The following is a description of a gene set: from publication Liberzon A, Birger C, Thorvaldsdóttir H, Ghandi M, Mesirov JP, Tamayo P (PMID 26771021) Genes down-regulated in response to ultraviolet (UV) radiation. species: Homo sapiens Human Gene Set: HALLMARK_UV_RESPONSE_DN, and this is the list of marker genes: DUSP1 (dual specificity phosphatase 1), CDC42BPA, MGLL, SRI, INPP4B, PIK3R3, DBP, ATRN, CCN1, AGGF1, FBLN5, SCAF8, NR3C1, CACNA1A, PRKCA, CDKN1B, ERBB2 (erb-b2 receptor tyrosine kinase 2), RND3, TJP1, MTA1, DDAH1, ATP2C1, PTPRM, FZD2, SPOP, RGS4, ATP2B4, PIK3CD, WDR37, ADGRL2, NIPBL, SCHIP1, PTPN21, LDLR, PIAS3, MIOS, INSIG1, ANXA4, RUNX1, SNAI2, DAB2 (DAB adaptor protein 2, NCBI Gene Id 1601), SYNJ2, SMAD7, SYNE1, PRKAR2B, RXRA, ATP2B1, COL11A1, DLG1, MAGI2, CDON, SIPA1L1, ABCC1, COL1A2 (NCBI Gene Id 1278), KALRN, SCN8A, COL3A1, PLPP3, KCNMA1, GJA1, RBPMS, DLC1, PRDM2, IGFBP5, TOGARAM1, TENT4A, GCNT1, SERPINE1, MAP2K5, NOTCH2, BCKDHB, PDGFRB, PHF3 (PHD finger protein 3), FYN, TGFBR3, VLDLR, F3, PEX14, CELF2, NEK7, MRPS31, BDNF, IGF1R, ADD3, CAP2, NR1D2, TGFBR2, MT1E, SMAD3, NRP1, ITGB3, ADORA2B, HAS2, EFEMP1, CAV1, PPARG, MGMT, VAV2, CDK13, PDLIM5, BMPR1A, AKT3, MET, BHLHE40, APBB2, GRK5, LPAR1, MAP1B, COL5A2, FHL2, ATXN1, ZMIZ1, ICA1, ARHGEF9, TFPI, PTGFR, DYRK1A (dual specificity tyrosine phosphorylation regulated kinase 1A), AMPH, LTBP1, MMP16, LAMC1, DMAC2L, MYC, PRKCE, RASA2, SLC22A18, ID1, CITED2 (Cbp/p300 interacting transactivator with Glu/Asp rich carboxy-terminal domain 2), YTHDC1, PMP22, NFKB1, IRS1, ATRX, ANXA2, SLC7A1, PTEN, KIT, SDC2, COL1A1, SFMBT1, ACVR2A, PLCB4, MAPK14, NFIB